The following is a description of a gene set: species: Homo sapiens Human Gene Set: GOBP_POSITIVE_REGULATION_OF_MIRNA_CATABOLIC_PROCESS Any process that activates or increases the frequency, rate or extent of miRNA catabolic process., and this is the list of marker genes: ZSWIM8 (zinc finger SWIM-type containing 8), LIN28B, MALAT1, XIST, DNM3OS, ZC3H12A, PNPT1, HOTTIP, NEAT1